The following is a description of a gene set: studied in species Mus musculus Mouse Gene Set: GOBP_PROTEIN_INSERTION_INTO_MEMBRANE The process that results in the incorporation of a protein into a biological membrane. Incorporation in this context means having some part or covalently attached group that is inserted into the the hydrophobic region of one or both bilayers., and this is the list of marker genes: Cox18, Emc8, Emc1, Tram1 (translocating chain-associating membrane protein 1), Rtp3, Grin3b, Mal, Get1, Emc9, Rtp4, Tomm22, Tomm40, Tram2, Emc3, Get4, Emc6, Sgta, Sec61a1, Tmem126a, Slc12a1, Emc7 (NCBI Gene Id 98979), Bax, Emc2, Emc4, Wdr83os, Rtp1, Get3, Bcs1l, Reep1, Bag6, Ncln, Nomo1, Tram1l1, Ccdc47, Wnk1, Oxa1l, Maip1, Tmco1, Moap1, Mmgt1, Caml, Rtp2, Rab5if, Ubl4a, Tmem147, Emc10